The following is a description of a gene set: species: Homo sapiens Regulation of pyruvate metabolism Human Gene Set: REACTOME_REGULATION_OF_PYRUVATE_METABOLISM, and this is the list of marker genes: PKM, PDK2, LDHA, RMND5B, PGAM5, PDP1, ME1, PDHA2, UBC, RANBP9, GID4, ARMC8, GSTZ1, UBB, PDP2, PDK4, RMND5A, PDK3, PDPR, PDHX, WDR26, MAEA, MKLN1, DLAT, DLD, SIRT4, GID8, PDHA1, UBA52, RPS27A, PDK1, PDHB, NEK1